Given this list of marker genes Retsat, Igfbp6, Lum, Ctnnb1, Mcl1, Timp3, Cyld, Dnajc3, Ifnb1, Tnfrsf12a, Ccnd1, Krt18, Ddit3, Plat, Fez1, Dnm1l, Sqstm1, Gpx3, Sod2, Ppp3r1, Dpyd, Etf1, Rela, Casp3, Bid, Ebp, Bnip3l, Sptan1, Bcl10, Timp1, Gstm2, Irf1, Bcap31, Tspo, Xiap, Jun, Hmox1, Erbb3 (NCBI Gene Id 97627), Btg3, Dap3, Aifm3, Casp7, Plcb2, Isg20, Sc5d, Casp9, Madd, Bik, Tgfbr3, Clu, H1f0, Sod1, Fdxr, Psen2, Gadd45a, Slc20a1, Eno2, Bcl2l2, Avpr1a, Tnfsf10, Tap1, Igf2r, Ereg, Il1b (interleukin 1 beta), Fas, Crebbp, Ppt1, Nefh, Diablo, Bmf, Gsr, Pea15a, Add1, Lef1 (lymphoid enhancer binding factor 1), Cth, Rara, Il6, Btg2, Rnasel, Emp1, Cdkn1a, Tgfb2, Pdcd4, Mmp2, Prf1, Psen1, Cdk2, Casp1, Satb1, Pmaip1, Gch1, Casp4, Erbb2, Hgf, Rhot2, Mgmt, Lmna, Gpx1, Bcl2l1, Ptk2, Dcn, Fasl, Sat1, Il1a, Cd14, Bcl2l10, Wee1, Cd38, Casp6, Casp2, Ccnd2 (NCBI Gene Id 97325), Dap, Hspb1, Txnip (thioredoxin interacting protein), Ppp2r5b (protein phosphatase 2, regulatory subunit B', beta), Gna15, Ifitm3, Timp2, Gucy2e (NCBI Gene Id 503686), Cdc25b, Hmgb2, Cd2, Birc3, Gpx4, App, Bcl2l11, Ccna1, Bgn, Ier3, Dnaja1, Il18, Vdac2, Rock1, Cd44, Bax, Egr3, F2, Pak1, Nedd9, Cflar, F2r, Smad7, Bmp2, Plppr4, Tnf, Gadd45b, Gsn, Pdgfrb, Rhob, Ifngr1, Lgals3, Dffa, Casp8, Ank, Cd69, Cav1, Cdkn1b, Anxa1, Top2a, Atf3, Brca1, here is a description of the gene set: from publication Howe DG, Blake JA, Bradford YM, Bult CJ, Calvi BR, Engel SR, Kadin JA, Kaufman TC, Kishore R, Laulederkind SJF, Lewis SE, Moxon SAT, Richardson JE, Smith C (PMID 30224793) Mouse genes annotated to HALLMARK_APOPTOSIS based on orthology mappings provided by the Alliance Genome Consortium studied in species Mus musculus Mouse Gene Set: HALLMARK_APOPTOSIS